The following is a description of a gene set: from publication Nakaya HI, Wrammert J, Lee EK, Racioppi L, Marie-Kunze S, Haining WN, Means AR, Kasturi SP, Khan N, Li GM, McCausland M, Kanchan V, Kokko KE, Li S, Elbein R, Mehta AK, Aderem A, Subbarao K, Ahmed R, Pulendran B (PMID 21743478) Human Gene Set: NAKAYA_MYELOID_DENDRITIC_CELL_FLUMIST_AGE_18_50YO_7DY_UP Here we have used a systems biology approach to study innate and adaptive responses to vaccination against influenza in humans during three consecutive influenza seasons. We studied healthy adults vaccinated with trivalent inactivated influenza vaccine (TIV) or live attenuated influenza vaccine (LAIV). TIV induced higher antibody titers and more plasmablasts than LAIV did. In subjects vaccinated with TIV, early molecular signatures correlated with and could be used to accurately predict later antibody titers in two independent trials. Notably, expression of the kinase CaMKIV at day 3 was inversely correlated with later antibody titers. Vaccination of CaMKIV-deficient mice with TIV induced enhanced antigen-specific antibody titers, which demonstrated an unappreciated role for CaMKIV in the regulation of antibody responses. Thus, systems approaches can be used to predict immunogenicity and provide new mechanistic insights about vaccines. Genes up-regulated in myeloid dendritic cell 7d vs 0d in young adults (18-50) after exposure to FluMist, time point 7D species: Homo sapiens, and this is the list of marker genes: BAG2, TACO1, ATP6V1C1, EIF2B3, IL13RA1 (NCBI Gene Id 3597), MAFF, HEBP2, ANG, LRRC47, CEP112, C1orf56, ACSF2, PDS5B, CD99, USP4, PTEN, TUG1, MRPL15, NSG1, ANAPC10, TXNL4A, ZNF331, ZFP36L2, ARHGEF2, RAB29, ADGRE5, PSMD5, ARFIP1, RAD51C, GLG1, AGO2, MCM3AP, PSD4, UBE3B, TSNAX-DISC1, TWF1, ETS2, FOXP1, ILVBL, FYB1, EOLA2, WDR45, CD151, ASH2L, CUEDC2, TXLNA, SS18, CMAHP (cytidine monophospho-N-acetylneuraminic acid hydroxylase, pseudogene), EHBP1, IDS, ABCF2, CNOT4 (NCBI Gene Id 4850), ATP8B4, SCAMP1, SCAND2P, TRABD, SLCO3A1, MTF1, LIAS, DCLRE1C, RECQL, SH3TC1, WASHC4, ANKLE2, UBE2Q1, NUMA1, CSF2RA, UBE3A, LILRA6 (NCBI Gene Id 79168), CDC5L, ANKRD12, IFRD1, TRIO, MAPK9, MCCC2, CZIB, EGR1, GPD2, TUBB4B, DNAJC13, HIP1, NOL8, USP7, TGFBR2, GPI, BUB1, GTF2A1, SLC39A9, PTGER4, NUP205, CD101, ACAP1, CDK11B, AATF, PSPH, ANKRD40, PAPSS2, DENND10, MRPS18B, FOXN2, CHN2, PPIE, MEF2A, ZNF408, C2CD3, EFNA4, RASA1, MKI67, POLR3C, CDK11A, PDE4DIP, FOSB, TMX4, ADGRG6, PTCD1, TUT7, KHNYN, HUS1, SPATA20, LRP5L, RAP2A, TRAM2, DDOST, UTP14A, PMVK, DNM2, SLC4A7, EIF3J, GTF2H5, MAGOH, TRIP11, MAP1LC3B, RABL2A (RAB, member of RAS oncogene family like 2A), IKBKB, MARCHF1, STK38L, GABBR1, TNNI2, ASCC3, EGR3, HEXIM1, CORO1B, PDSS1, NABP1, CEP192, MTDH, SUV39H1, ANKS1A, RPL26L1, GLYR1, DOK2, TBL1XR1, ENGASE, IL18R1, SIGLEC7, RABL2B, HPS1, CREBL2, KLF9, GRAMD2B, IVNS1ABP, AOAH, GCDH, SYNC, RUNX1, MAP3K2, DVL2, VPS4A, CRK, POLR2H, HNRNPA0, GAPVD1, TSC22D3, FRAT1, C2orf49, FTSJ1, PTGS2, GNAL, RFXAP, ALDH3A2, DNPH1, CEBPD, CCND3, VCAN, TNPO1, SOS2 (SOS Ras/Rho guanine nucleotide exchange factor 2), LRRC41, AXL, RRP9, STX6, TLR8, RAD50, ACACB, ADSL (adenylosuccinate lyase), MAPKAPK5-AS1, RCBTB2, MPZL1, DENND4B, FLII, PTAFR, MOSPD3, SMYD2 (NCBI Gene Id 56950), GNL3L, MACF1, ELP3, LILRB1, CD36, SUGP2, ECH1, CAPN7 (calpain 7), EOLA1, ALDOC, IBA57, ZNF518A, CCNG1, CLTB, SKIL, STAU2, PON2, NR4A2, JADE2, GPD1L, STX16, TUBB, MED6, TTC3 (tetratricopeptide repeat domain 3), AGL, ZNF142, NIPAL2, BBLN, TIMM9, PLAUR, PDCD6, GSK3B, KLHDC10, HIPK2, TBRG4, TCF20, RNF24, SYMPK, TRIM14, KLF12, CALM1, LSM5, PRDM2, SNAPC3, FKBP5, HAX1, PLXND1, PI4KB, PQBP1, PPIA, CLK3, ZNF419, ELOB, PLN, CTSW, KANSL3, CELF1, CYTH1 (cytohesin 1), TAF12, PRKCA, RAD51B, STX17, CCSER2, PCGF2, PAQR3, RGS1, ST6GAL1, DEXI, LMO4, EVI5, FOXJ3, AKAP10, JUN, F13A1, EXOC7, SLC35A3 (solute carrier family 35 member A3, NCBI Gene Id 23443), PDF, DDX27, MSR1, SEZ6L, FAM124B, CNTRL, ULK2, TRAPPC4, PRKCI, VAMP1, SCN9A, ADISSP, SH3BP4, RHOC, TMPO, RTN1, CYP51A1, ME3, RNFT1, KLF6, PLCB2, BEST1, PIGP, CEP350, LUC7L, ACADVL, SLC24A1, SDHC, LDLRAD4, COQ6, SPATA6 (spermatogenesis associated 6), MIA3, FBXW10B, LRIG1, RUSC1, DLX4, ERMAP, CRIP1, SPTLC2, SUPT20H, ACTN1, FOS, ASNSD1, MICU1, ZNF175, AGO1, MUS81, RASA2, CRYL1, VWA8, SHQ1, BRD4, TRNAU1AP, NUP155, CDK16, RTRAF, PIGB, BPTF (NCBI Gene Id 348241), COG8, DISC1, KDM4B, ETNK1, CDS2, ISG20L2, SOCS3, C2CD2L, AREG, SAFB2, SUPT7L, LILRB3, PLPP1, GORASP2, AP3S2, VEZF1, IDI2-AS1, TOR1AIP1, ARHGAP25, DGKA, POP5, MAPK1, IFNAR1, TCAF1, HDAC4, SOD2 (superoxide dismutase 2), CSNK2A1, RAP2B, ROBO3, AKT3, RETREG2, HTR7, ST8SIA4, RIC8A, PRDM4, TESC, RXRB, STK3 (NCBI Gene Id 6788), MFN1, DCAF1, TAF4, CASP2